Given this list of marker genes POLE, ADH5, POMC, SIX3, MKS1, CCDC22, WASHC5, CILK1, CDKN1C, LTBP4, ZMPSTE24, TNXB, CDON, NSDHL, PEX1 (NCBI Gene Id 7788), PROKR2, HESX1, TBX19, VPS35L, SAMD9, MTHFR, WDR11, NUAK2 (NUAK family kinase 2), NR0B1, BCAP31, DPYSL5, GLI3, LMNA, GPR161, TBC1D7, ABCD1, VANGL2, LHX4, ROBO1, BMP4, CYP11A1, here is a description of the gene set: studied in species Homo sapiens Developmental hypoplasia of the adrenal glands. Adrenal hypoplasia Human Gene Set: HP_ADRENAL_HYPOPLASIA